The following is a description of a gene set: species: Homo sapiens Activation of the lectin pathway (LP) is initiated by Mannose-binding lectin (MBL), the hetero-complex CL-LK formed from COLEC11 (Collectin liver 1, CL-L1) and COLEC10 (Collectin kidney 1, CL-K1), and the ficolins (FCN1, FCN2, FCN3). All are Ca-dependent (C-type) lectins that initiate the complement cascade after binding to specific carbohydrate patterns on the target cell surface. All form trimers and larger oligomers. MBL and ficolins circulate in plasma as complexes with homodimers of MBL-associated serine proteases (MASP). MASP1, MASP2 and MASP3 have all been reported to mediate complement activation. Upon binding of human lectin to the target surface, the complex of lectin:MASP undergoes conformational changes that result in MASP cleavage and activation (Matsushita M et al. 2000, Fujita et al. 2004). Active MASP2 cleaves C4 to generate C4a and C4b. C4b binds to the target cell surface via its thioester bond, then binds circulating C2. Bound C2 is cleaved by MASP2 to yield the C3 convertase C4b:C2a. The active form of MASP1 was reported to cleave C2 in a manner similar to MASP2. MASP1 can cleave proenzyme MASP2, leading to complement activation. MASP1 can also cleave fibrinogen to yield fibrinopeptide B, and activates factor XIII. MASP1 may have a role in removal of 'dead C3', i.e. C3(H2O). In addition to MASP1 to 3, two alternatively-slpiced forms of MASP1 (MAp44) and MASP2 (sMAP) have been implicated in complement cascade signaling. The functions of MASP3, sMAP and MAp44 in the lectin pathway remain to be clarified. part of: Creation of C4 and C2 activators Reactome Pathway: Lectin pathway of complement activation, and this is the list of marker genes: SARS coronavirus, complete genome, COLEC11, S, FCN2, M, FCN1, 7a, FCN3, 3a, MASP2, COLEC10, MBL2, E, N, MASP1